The following is a description of a gene set: species: Homo sapiens Human Gene Set: HP_ABNORMAL_FALLOPIAN_TUBE_MORPHOLOGY Abnormal fallopian tube morphology An abnormality of the fallopian tube., and this is the list of marker genes: RAD51 (NCBI Gene Id 5888), NDUFB11, BRCA2, HCCS, TP53, MRE11, DHH, CHEK2, WT1, BRCA1, KIF7, PTEN, BARD1, RAD50, PALB2 (partner and localizer of BRCA2), PLG, RAD51C, WNT4, RAD51D, BRIP1, NBN, HYLS1, FANCB (FA complementation group B), WNT3, DCAF17, COX7B, AR